The following is a description of a gene set: Mouse genes annotated to increased lymphoblastic lymphoma incidence (MP:0009320) retrieved from the Mouse Genome Informatics database via MouseMine studied in species Mus musculus Mouse Gene Set: MP_INCREASED_LYMPHOBLASTIC_LYMPHOMA_INCIDENCE from publication Motenko H, Neuhauser SB, O'Keefe M, Richardson JE (PMID 26092688), and this is the list of marker genes: Tal1, Msh2, Notch3, Mir155 (microRNA 155), Ptpn11, Kras